Given this list of marker genes NDUFA4L2, MT-CO1, COX7A2, NDUFA4, COX6A1, COX7B, COX7C, COX6B1, MT-CO2, COX6C, COX5B, COX4I2, COX7B2, MTCO2P12, COX8C, COX5A, COX7A2L, MT-CO3, COX7A1, COX7A2P2, COX6A2, COX4I1, COX8A, C15orf48, COX6B2, here is a description of the gene set: Human Gene Set: GOCC_RESPIRATORY_CHAIN_COMPLEX_IV species: Homo sapiens A part of the respiratory chain, containing the 13 polypeptide subunits of cytochrome c oxidase, including cytochrome a and cytochrome a3. Catalyzes the oxidation of reduced cytochrome c by dioxygen (O2).